The following is a description of a gene set: The chemical reactions and pathways resulting in the breakdown of any purine ribonucleoside, a nucleoside in which purine base is linked to a ribose (beta-D-ribofuranose) molecule. species: Mus musculus Mouse Gene Set: GOBP_PURINE_RIBONUCLEOSIDE_CATABOLIC_PROCESS, and this is the list of marker genes: Uox, Urah, Urad, Pnp, Ahcy, Pnp2, Ahcyl, Adal, Enpp4 (ectonucleotide pyrophosphatase/phosphodiesterase 4), Xdh, Ada